Given this list of marker genes ST6GALNAC5, ST6GAL2, C20orf173, ST3GAL6, ST8SIA1, ST3GAL5, ST3GAL4, ST3GAL2, ST8SIA2, ST3GAL3, ST8SIA4, ST6GALNAC4, ST8SIA5, ST6GALNAC6, ST6GALNAC3, ST6GALNAC1, ST8SIA3, ST3GAL1, ST6GAL1, ST6GALNAC2, ST8SIA6 (ST8 alpha-N-acetyl-neuraminide alpha-2,8-sialyltransferase 6), here is a description of the gene set: Human Gene Set: GOMF_SIALYLTRANSFERASE_ACTIVITY Catalysis of the transfer of sialic acid to an acceptor molecule, typically the terminal portions of the sialylated glycolipids (gangliosides) or to the N- or O-linked sugar chains of glycoproteins. species: Homo sapiens